The following is a description of a gene set: Vitamins A, D, E and K are lipophilic compounds, the so-called fat-soluble vitamins. Because of their lipophilicity, fat-soluble vitamins are solubilised and transported by intracellular carrier proteins to exert their actions. Alpha-tocopherol, the main form of vitamin E found in the body, is transported by alpha-tocopherol transfer protein (TTPA) in hepatic cells (Kono & Arai 2015, Schmolz et al. 2016). Reactome Pathway: Vitamin E transport part of: Metabolism of fat-soluble vitamins studied in species Homo sapiens, and this is the list of marker genes: TTPA